Given this list of marker genes SLC29A1, SLC29A4, SLC6A2, SLC6A15, SLC22A2, CPLX3, SLC6A16, SLC17A8 (solute carrier family 17 member 8), SLC18A3, SLC17A7, SLC6A3, SLC28A2, SLC29A3 (NCBI Gene Id 8072), SLC22A4, SLC6A4, SLC17A6, SLC22A3, SLC22A1 (NCBI Gene Id 6580), GABRQ, SLC29A2, here is a description of the gene set: studied in species Homo sapiens Human Gene Set: GOMF_NEUROTRANSMITTER_TRANSMEMBRANE_TRANSPORTER_ACTIVITY Enables the directed movement of a neurotransmitter into, out of or within a cell, or between cells. Neurotransmitters are any chemical substance that is capable of transmitting (or inhibiting the transmission of) a nerve impulse from a neuron to another cell.